The following is a description of a gene set: studied in species Homo sapiens from publication Chen Y, Wang X (PMID 31504780) Genes predicted to be targets of miRBase v22 microRNA hsa-miR-3140-3p in miRDB v6.0 with MirTarget v4 prediction scores > 80 (high confidence targets). Human Gene Set: MIR3140_3P, and this is the list of marker genes: ZFX, PRKX, KCNIP3, AVL9, PSG5, TMEM167A, AQP4, C21orf91, PAK3, PCDH10, SEMA3C, AEBP2, SON (NCBI Gene Id 84155), C4orf3, FAM3C, AKNAD1, ASPH, CAAP1, CDH6, KL, DAZ2, OSBPL1A, CTNNA2, PTGDR, SH3BGRL, ARID4B, ECT2, PAN3 (NCBI Gene Id 376186), SEMA5A, CDC37L1, SEMA6A, NRG1, PHF8, RTL8B, CCNT2, TENT5D, COMMD3-BMI1, LHFPL6, GOLT1B, ARHGAP26, AFTPH, ZSCAN12 (zinc finger and SCAN domain containing 12), ZNF34, CAMSAP2, NNT, LSG1, PCDH17, MBTPS2, PIEZO2, VPS35L, KGD4, RBPJ, TENT4B, SNX18, PDE1C, COL4A2-AS2, PPP1R3B, SYT14, PPP4R3A, EPB41L1, ASAP2, PI4K2B, KIF23, C2orf49, STXBP5L (syntaxin binding protein 5L), CDK15, RSBN1, TENM1, RAB23, GRM5, GGPS1, CDK6, CR1, SLC24A2, C2orf69, ATG4A, SYNJ1, UNC5D, CAV2, ST18, TMCO1, DISC1, CDKN1B, NCOA4, PACC1, CYBRD1, PCGF3, RPGRIP1L, TTLL2, YIPF4, RBM26 (RNA binding motif protein 26), SLC6A6, PTRH2, KHDRBS1, GUCY1A2, FMO2 (flavin containing dimethylaniline monoxygenase 2), EGR3, RNF128, MED21, MINDY2, MIER3, TMEM201, GRIA3, CROT, SARAF, SLC16A12, TET1, CTNNA3, KLF5, PRPF40A, DCTN5, GABRB2, CHMP1B, ZFP42, CEP135, MXD1, ASF1B, AMFR, TMEFF2, RB1CC1, ARHGAP42, TM4SF20, TLCD3A, ADGRL3, RPS6KA5, AP2B1, GPR137C, XKR6, MME, C6orf47, NEGR1, FEM1B, ZMIZ1, VTI1A, PTPRT, GALNT3, WWC2, NR3C1, RGS13, HECTD2, PHEX, VSNL1, VPS37A, PEX5L, UBLCP1, TCF7L2 (NCBI Gene Id 6934), CCNE1, MCF2L, DNAI4, KCTD4, INTS6, AKT3, XIAP, SGCD, THUMPD2, UBE2O, CBFA2T3, TULP4, ACSL3, ICA1L, IFT57, ASH1L (NCBI Gene Id 55870), WNT2B, APOL4 (apolipoprotein L4), MOSMO, TAB2, BMPR2, BICRAL, MCFD2, ELMOD2, FNIP2, GLRA3, PCNP, GINS4, ELK4, PAK6, HS3ST2, SLC2A1, WDR26, MBTD1, PURB, FZD3, LAMA3, MPP1, DYRK1A, FBXO28, SHC3, SLC35F1, TRIM2, SLC9A4, TTC1, TSPAN9, CREBRF, GRIP2, C1orf21 (chromosome 1 open reading frame 21), KCNB1, ANO4, KRBOX4, LPGAT1, JAM3, STXBP5 (NCBI Gene Id 134957), E2F1, FAM217B, KCNQ3, GOLGA3, RBM12, RCBTB1, ELL2, UBE2N, PSMD11, IGSF10 (NCBI Gene Id 285313), MAGI2, MAP3K2, GFRA1, ZSWIM6, OPCML, PRDM5, ZFPM2, CSTF1, UNC13A, KLF3, ASXL3 (ASXL transcriptional regulator 3), ATXN7, RBMS3, SNX3, IGDCC4, RORB, CD55, ZC2HC1B, RHBDD1, KLF12, RNASEL, LPAR1, CCNG1, ZNF721, PDK3